The following is a description of a gene set: Mouse Gene Set: GOBP_POSITIVE_REGULATION_OF_SYNAPTIC_VESICLE_FUSION_TO_PRESYNAPTIC_ACTIVE_ZONE_MEMBRANE studied in species Mus musculus Any process that activates or increases the frequency, rate or extent of synaptic vesicle fusion to the presynaptic membrane., and this is the list of marker genes: Prrt2, Syt13, Rph3al, Erc2, Rimbp2, Doc2g, Erc1, Syt11, Cacna1b, Doc2a, Syt7, Syt5, Rph3a, Syt2, Syt9, Syt4, Rims2, Syt8, Rims1, Syt1, Doc2b